The following is a description of a gene set: Human Gene Set: KEGG_MEDICUS_REFERENCE_ATR_P21_CELL_CYCLE_G2_M species: Homo sapiens ATR-p21-Cell cycle G2/M. Pathway ID: N00499. Pathway type: Reference. Pathway class: nt06230 Cell cycle. Pathway Definition from KEGG: (ATM,ATR) -> CHEK1 -> TP53 => CDKN1A -| (CDK1+CCNB), and this is the list of marker genes: CHEK1, CDKN1A, ATR, CCNB1, CCNB3, ATM, CCNB2, TP53, CDK1